The following is a description of a gene set: Base excision repair studied in species Homo sapiens Human Gene Set: WP_BASE_EXCISION_REPAIR, and this is the list of marker genes: PARP2, PARP1, NEIL2, POLE3, POLL, POLE4, SMUG1, POLD2, NTHL1, FEN1 (flap structure-specific endonuclease 1), LIG3, PCNA, APEX2, POLB, TDG, POLD3, POLE2, MUTYH, LIG1, HMGB1, MBD4, OGG1, UNG, POLD1, XRCC1, APEX1, PNKP, MPG, NEIL3 (nei like DNA glycosylase 3), POLE, POLD4